Given this list of marker genes CSN2, ACTG2, DMC1, ZNF273, TKTL1, ADAM22, IL15, IL12B, GTPBP10 (GTP binding protein 10), CAMTA1, FETUB, AKR1B1, SEC31B, ART1, MMRN1, CD163, KCNA4, ZNF211, THOC2, GABRB1, LZTR1, TNFAIP6, AMOTL2, NPR1, CLK3, CNR1, FOXG1, LEP, KCNE1, AKR1A1, IL1B, SOX15, LBX1, RRN3, CCL20, DRP2, TLK2, EDC4, ACSM1, GPR4, PLAUR (NCBI Gene Id 5329), NFKB2, CCR7 (NCBI Gene Id 1236), LDB3, CD44, CCDC22, PTPN1, RHOA, ENOX2, RXRG (retinoid X receptor gamma), KIAA0087, SLC31A2, ANXA5, MS4A1, PTGES, CA6, UPP1, SAMD4A, SOD2, STAT4, TNK1 (NCBI Gene Id 8711), BBS4, TFF2, TRIAP1, CCN2, MTMR9, C1orf105, FSCN2, FOXD1, REG1CP, CHPF, FLOT2, LITAF, CYTH2, CYP7A1, H2BC7, GALK2, PDPN, HOXD3, YIPF4, MSTN, DTX2, CXCL8, ERC1, S100B, AFM, CCT6B, FGF7, TRAT1, LCP2, DICER1, FBXO7 (NCBI Gene Id 25793), PIP, FABP3, ACP2, PTGFR, TNIP1, CDH11, TLN2, SCN1B, PTGS2, SH2D2A, SUN1, ZBTB43, AQP8, PDE1A, FGF3, ABCA4, ACADS, CRHR1, MOK, WDR7, ACTN1, BAAT, NBR1, CKB, CIB2, HOXD9, CEP152, PON1, DNAH7, SYN2, PNLIPRP2, MSC, OPTN, MEP1A, DLST, PWAR5, PSMD9, ATG4A, PLN, AQP3, GIPR, STOM, LAMB3, SLC18A2, SLC25A26, MYOZ2, MISP, PPBPP2, PEX5, PLA2G2A, ZIC3, ALG13 (NCBI Gene Id 79868), CYB5R3, FAS, CRK, CYBA, DIPK1A, CCNT2, OMD, STX1A, GFRA1, SLC17A7, LYRM9, SH3BP1, MPHOSPH8, DRG2, TXNRD1, OIP5, PTPN4, RASSF8, RTCA, RFPL3S, PPP1R13B, IL18, POU2AF1, LIMK2, PRR4, CHD1L, RPGRIP1, TMCO1, RELB, PIGO, ARHGEF2, AHNAK, FCN3, CSDC2, KCNMA1 (potassium calcium-activated channel subfamily M alpha 1), CSF2, RNF144A, PPP2R2B, IBTK, CTNND1, TNFAIP2, TLR1, CALCA, HCK, GNLY, ATAD2B, SORCS3, PCOLCE, PLA2G7, BMP10, OAZ2, PARP2, CLDN3, here is a description of the gene set: Genes up-regulated in comparison of macrophages exposed to L. major versus macrophages exposed to T. gondii. species: Homo sapiens Monocyte-derived dendritic cells (DC) and macrophages (MΦ) generated in vitro from the same individual blood donors were exposed to five different pathogens, and gene expression profiles were assessed by microarray analysis. Responses to Mycobacterium tuberculosis and to phylogenetically distinct protozoan (Leishmania major, L. donovani, Toxoplasma gondii) and helminth (Brugia malayi) parasites were examined, each of which produces chronic infections in humans yet vary considerably in the nature of the immune responses they trigger. from publication Chaussabel D, Semnani RT, McDowell MA, Sacks D, Sher A, Nutman TB (PMID 12663451) Human Gene Set: GSE360_L_MAJOR_VS_T_GONDII_MAC_UP